Given this list of marker genes MLF1, KIT, HMGB1, DPF2, FLT3, SPI1, SP3, BRAF, ANKLE1, JAM3, here is a description of the gene set: The process in which a precursor cell type acquires the specialized features of a myeloid progenitor cell. Myeloid progenitor cells include progenitor cells for any of the myeloid lineages. Human Gene Set: GOBP_MYELOID_PROGENITOR_CELL_DIFFERENTIATION species: Homo sapiens